Given this list of marker genes KCNE2, SERF2, ENSG00000225555, CLIC6, MTFP1, CCKBR, CBLIF, IZUMO1, SIGLEC11, UQCRQ, SLC19A2, NUPR2, HIP1R, ODAM, ATP11B, GREM2, CYB5R1, TXNDC17, GLOD4, MTATP6P1, TFF1, GPR155, SIK2, MTCO3P12 (MT-CO3 pseudogene 12), ATP4A, HPCAL1, SMIM11, MRPS18A, CLCNKA, RPL17P7, GNL3LP1, GBGT1, ETNPPL, NDUFS3, TMPRSS2, PWWP2A, SLC26A9, LINC02381, STAU1, SLC16A7, KCNJ16, LASP1, STARD10, SAMD13, FA2H, FAHD2B, COMTD1, FGD4, COX6A1, RAF1, EPN3, ZNF57, LINC01679, PLEKHB2, MRPL41, CCNJL, CATIP-AS2, ATP5PO, TBRG4, CAPN13, TMEM161B, RPS21P4, GPT2, NDUFS1, SLC9B1P2, TMEM116, LHFPL7, LINC01847, TDH-AS1, CSNK2A3, KCNQ1, DUSP4, TMEM86B, MAP3K21, TRNP1, MRPL12, FXYD4, MRPS18B, PPP2R1B, B4GALNT3, GPX2, CLEC3A, MCRIP2 (NCBI Gene Id 84331), ANKRD16, BCAT2, C9orf152, SLC9A3-OT1, NR0B2, ARHGEF28, ATP4B, RAP1GAP2, FUT1, PRDM16-DT, STX12, PRR13, GCNT2, HK2, SGK2, PPARGC1B, FAM162A, PCAT18, MTND4P35, GRIP2, MFSD4A, PHLDA1, INTS13, AK3, PNPLA1, KLF11, NFE2L2, PXMP2, ESRRG, GPRC5C, ENSG00000254055, MAP4K3-DT, MTATP6P2, PFKFB2, CKB, MISP3, VSIG2, ACSL3, ATP5ME, RPL21P65, MCF2L-AS1, GATA6-AS1, TRIM50, PSCA, here is a description of the gene set: from publication Cao J, O'Day DR, Pliner HA, Kingsley PD, Deng M, Daza RM, Zager MA, Aldinger KA, Blecher-Gonen R, Zhang F, Spielmann M, Palis J, Doherty D, Steemers FJ, Glass IA, Trapnell C, Shendure J (PMID 33184181) species: Homo sapiens Marker genes curated from the annotated cluster as represented in the Descartes Human Gene Expression During Development database. The gene expression program underlying the specification of human cell types is of fundamental interest. The study authors generated human cell atlases of gene expression and chromatin accessibility in fetal tissues. For gene expression, the study authors applied three-level combinatorial indexing to >110 samples representing 15 organs, ultimately profiling ~4 million single cells. The study authors leveraged the literature and other atlases to identify and annotate hundreds of cell types and subtypes, both within and across tissues. Our analyses focused on organ-specific specializations of broadly distributed cell types (such as blood, endothelial, and epithelial), sites of fetal erythropoiesis (which notably included the adrenal gland), and integration with mouse developmental atlases (such as conserved specification of blood cells). These data represent a rich resource for the exploration of in vivo human gene expression in diverse tissues and cell types. Human Gene Set: DESCARTES_MAIN_FETAL_PARIETAL_AND_CHIEF_CELLS